The following is a description of a gene set: The appearance of interleukin-18 due to biosynthesis or secretion following a cellular stimulus, resulting in an increase in its intracellular or extracellular levels. studied in species Homo sapiens Human Gene Set: GOBP_INTERLEUKIN_18_PRODUCTION, and this is the list of marker genes: DHX9, GBP5, GSDMD, NLRP12, IL10, CASP1, TNF, MIR411, CD84, TLR9, MIR197, USP50, TLR2, NLRP9